The following is a description of a gene set: studied in species Homo sapiens The lipid bilayer surrounding a clathrin-coated vesicle. Human Gene Set: GOCC_CLATHRIN_COATED_VESICLE_MEMBRANE, and this is the list of marker genes: SLC18A3, EREG (NCBI Gene Id 2069), IGF2R, NRGN, MYCBPAP, AP1M2, HLA-DPB1, MYO6, ATP6AP1, AP2M1, ATP6V1H, HLA-DRB1, CD9, CLBA1, ADRB2, AP4B1, KIAA0319, APOB, HLA-DRB3, CLTA, SYNRG, TGOLN2 (trans-golgi network protein 2), ATP6V0D1, VAMP4, AP1G2, IL7R, EPN1, SH3GL2, ARC, DAB2, VAMP3, AP3B2, AVPR2, SLC32A1, LDLRAP1, CD4, ATP6V0C, EPN2, ATP6V1F, CLTC, M6PR, BTC, ATP6V1E1, ADCY8, FZD2, AP3B1, BTBD8, EGF (epidermal growth factor), SGIP1, VAMP7, SCARB2 (scavenger receptor class B member 2), CD3G, TYRP1, HLA-DPA1, CFTR, STON1, SYT2, AP1B1, FCGR1BP, AP1S2 (adaptor related protein complex 1 subunit sigma 2), AP1S1, TBC1D5, NECAP2, SLC18A2, HBEGF, REEP6, RAB35, HLA-DRA, SLC17A7, STON2, HLA-DQB2 (NCBI Gene Id 3120), HIP1R, HLA-DQB1, ATP6V0B, HLA-DQA2, AP1G1, ATP6V1B2, SLC18A1, AP2B1, EGFR, AFTPH, WNT5A, HIP1, GAD1, HLA-DQA1, ATP6V0A1, NECAP1, ENTHD1, CLINT1, NCALD, CLTCL1, CEMIP, HSPA8, AP2A1, LRP2, HLA-DRB4, VAMP2, ATP6V0E2, LDLR, ATP6V1G2, ATP6V1C1, EPS15, DENND1A, SYT11, RASSF9, EPN3, CLTB, AP1S3, AP1M1, CHRM2, EPGN, SLC2A8, APOE, TFRC, DNAJC5, CD207, ROR2, DBNL, TF, CD3D, ATP6V1D, VAMP8, RAB3A, ATP6AP2, RNASEK, FCGR1A, AP2A2, ATP6V1A, FZD5, HLA-DRB5, AP2S1, RAB5A, AVP, TGFA, SYT1, SYT9, CD74, AREG, GAD2, FZD4